Given this list of marker genes CTNS, PUS3, PKHD1, METTL27, GTF2IRD2, DPH2, SLC7A7, VPS37D, REN, MT-TV, DNAJC30, MT-ATP6, NPHP3, TULP3, TMEM67, CLCNKB, STX1A, ALMS1, RFC2, FOXC2 (NCBI Gene Id 50824), ACP5, NUP107, IFT122, GBE1, TBL2, XPNPEP3, NPHP1, MT-ND4, SHPK, SLC30A9, GLA, MRPS22, AGT, LAMB3, INVS, FAN1, MUC1 (mucin 1, cell surface associated), FOXP3, MRPL3, WDR19, ACE, SLC12A3, CPT2, PMM2, VPS33A, MT-ND6, CLCN5, SLC2A9, RPGRIP1L, DCDC2, CRB2, UMOD, MT-ND1, ANTXR1, MMUT, MT-ND2, NUP133, NPHP4, EIF4H, FKBP6, SEC61A1, ITGA3 (integrin subunit alpha 3), GLIS2, SLC37A4, ELN, MT-ND3, LAMA3, SLC41A1 (NCBI Gene Id 254428), MYO1E, GTF2I, TMEM270, BCS1L, LAMC2, BTNL2, NCF1, MT-ND5, NPHS1, TRAF3IP1, CLIP2, MT-TW, BUD23, AGTR1, CEP83, HLA-DRB1, DPH1, NDUFAF6, SLC22A12, LIMK1, PTPRO, OCRL (OCRL inositol polyphosphate-5-phosphatase), VPS33B, MT-TK, BSND, BAZ1B, GTF2IRD1, MT-TL1, here is a description of the gene set: studied in species Homo sapiens Human Gene Set: HP_ABNORMAL_RENAL_TUBULE_MORPHOLOGY An abnormality of the renal tubules. Abnormal renal tubule morphology